The following is a description of a gene set: NGF stimulation induces expression of a wide array of transcriptional targets. In rat PC12 cells, a common model for NGF signaling, stimulation with NGF causes cells to exit the cell cycle and undergo a differentiation program leading to neurite outgrowth. This program is driven by the expression of immediate early genes (IEGs), which frequently encode transcription factors regulating the activity of NGF-specific delayed response genes. Reactome Pathway: NGF-stimulated transcription studied in species Homo sapiens part of: Nuclear Events (kinase and transcription factor activation), and this is the list of marker genes: TCF12, CDK5R1, ID2, JUND, SGK1, ID4, NAB2, JUNB, SH3GL3, ID1, RRAD, CDK5, SRF, TRIB1, ATF2, ATF1, EP300, FOSL1, ID3, ASCL1 (achaete-scute family bHLH transcription factor 1), EGR3, CHD4, CDK5R2, FOS, ARC, MEF2D, VGF, EGR2, TPH1, FOSB, ELK1, LYL1, REST, DNM2, CREB1, NAB1, F3, EGR4 (NCBI Gene Id 82930, early growth response 4), EGR1